The following is a description of a gene set: Using advanced gene targeting methods, generating mouse models of cancer that accurately reproduce the genetic alterations present in human tumors is now relatively straightforward. The challenge is to determine to what extent such models faithfully mimic human disease with respect to the underlying molecular mechanisms that accompany tumor progression. Here we describe a method for comparing mouse models of cancer with human tumors using gene-expression profiling. We applied this method to the analysis of a model of Kras2-mediated lung cancer and found a good relationship to human lung adenocarcinoma, thereby validating the model. Furthermore, we found that whereas a gene-expression signature of KRAS2 activation was not identifiable when analyzing human tumors with known KRAS2 mutation status alone, integrating mouse and human data uncovered a gene-expression signature of KRAS2 mutation in human lung cancer. We confirmed the importance of this signature by gene-expression analysis of short hairpin RNA-mediated inhibition of oncogenic Kras2. These experiments identified both a pattern of gene expression indicative of KRAS2 mutation and potential effectors of oncogenic KRAS2 activity in human cancer. This approach provides a strategy for using genomic analysis of animal models to probe human disease. studied in species Homo sapiens Human Gene Set: SWEET_KRAS_ONCOGENIC_SIGNATURE from publication Sweet-Cordero A, Mukherjee S, Subramanian A, You H, Roix JJ, Ladd-Acosta C, Mesirov J, Golub TR, Jacks T (PMID 15608639) Genes that contributed maximally to the GSEA score of the up-regulated gene set from the KrasLA mouse model in two human lung cancer expression data sets comparing mutant vs normal KRAS., and this is the list of marker genes: MANF, TANK, BTG1, RPL14, LCN2, LGALS3, CST3, RPL8, EIF3E, SLC25A5, HPN (NCBI Gene Id 3249), EEF1D, PHLDA1, RPL6, PON2, CCND1, S100A1, FAM3C, TNNT1, ID2, GFUS, MDFI, MTIF2, ATP1B1, ITGB2, NPC2, CTSS, PSEN1, MYCN, FCGR2A (NCBI Gene Id 90764), GADD45A, MYH7, HIF1A, PCBD1, PABPC1, CDKN1A, BSG, MRC1, EEF2, ATP5PB, RPS2, RPL3, PHLDA2 (NCBI Gene Id 7262), KRT8, EEF1B2, UBXN1, HNRNPA1, MAN1A1, LAMC1, FKBP2, NUP88, DUSP6, BOP1, CITED2, KDELR1, TGOLN2, SLC12A2, IL18, HNF1B, AXIN1, SIRPA, TGFBI, GLRX, ACLY, CEACAM1, PHB2, RO60, KRT18, SHC1, VASP, RACK1, PAFAH1B3, MT2A, SND1, GABPB2, RABGGTB, FEZ2, NMT1, HLA-DQA1, ITGAM, GNS, PLIN2, NPR2 (natriuretic peptide receptor 2), SFTPB, CSF2, CD68, PDK3, TYR, MAPK1